The following is a description of a gene set: The directed movement of organic cations into, out of or within a cell, or between cells, by means of some agent such as a transporter or pore. Organic cations are atoms or small molecules with a positive charge which contain carbon in covalent linkage. studied in species Mus musculus Mouse Gene Set: GOBP_ORGANIC_CATION_TRANSPORT, and this is the list of marker genes: Slc43a1, Slc1a1, Slc7a8, Pou2f2, Slc6a7, Slc66a1, Slc25a2, Slc22a3, Slc44a4, Slc6a5, Slc16a9, Slc19a3, Slc22a16, Slc44a2, Slc25a42, Sfxn3, Slc44a1, Slc17a8, Scn4a, Slc5a7, Flvcr1, Rgs4, Slc1a2, Slc35f3, Slc22a5, Stx1a, Psen1 (presenilin 1), Llgl2, Agtr2, Adora3, Rhag, Slc25a17, Snca, Agt, Slc44a3, Ghsr, Arg1, Slc7a10 (solute carrier family 7 (cationic amino acid transporter, y+ system), member 10), Slc22a2, Ly6e, Slc11a1, Slc6a3, Slc7a7, Nisch, Slc22a21, Oxtr, Slc7a2 (NCBI Gene Id 11988), Slc36a4, Slc47a1, P2ry12, Slc22a1, Slc38a1, Slc7a6, P2ry1 (NCBI Gene Id 18441), Sfxn2 (NCBI Gene Id 98151), Slc6a9, Slc36a2, Crh (corticotropin releasing hormone), Atp13a3, Slc32a1, Slc29a3, Slc36a1, Slc44a5, Slc6a14, Htr6, Mfsd12, Gck, Slc6a17, Slc1a4, Slc18a3, Aqp8 (NCBI Gene Id 11833), Plcd1, Slc22a4, Adora2b, Comt, Crhr1, Slc25a26, Slc29a4, Slc6a6, Hrh3 (histamine receptor H3), Ffar3, Slc38a3, Slc38a2, Slc3a2, Slc19a2, Adora2a, Rgs2, Chrna3, Slc38a9, Cacna1a, Kcnb1, Nfe2l1, Slc25a19, Slc38a5, Tacr2, Slc36a3, Ptgs1, Slc6a20a (NCBI Gene Id 210451), Cln3, Slc7a3, Abcb1a, Slc25a38, Slc1a5, Slc6a12, Chrna7, Slc16a10, Slc6a2, Cltrn, Slc38a4, Arg2, Tspo2, Flvcr2, Slc25a15, Slc15a4, Slc47a2, Slc6a15, Slc7a1, Vip, Gabbr1, Slc6a20b, Slc25a29, Slc25a20, Htr2c, Nfkbie, Sfxn1, Slc18a1, Slc43a2, Crhr2, Slc18b1, Sec14l1, Ptger3, Actb, Ralbp1, Arl2, Cartpt, Ace2, Oxt, Slc7a5